The following is a description of a gene set: Any process that modulates the frequency, rate or extent of the phosphorylation of peptidyl-tyrosine. species: Homo sapiens Human Gene Set: GOBP_REGULATION_OF_PEPTIDYL_TYROSINE_PHOSPHORYLATION, and this is the list of marker genes: SOCS4, TNFSF18 (TNF superfamily member 18), VEGFA, PARP9, INPP5F, VPS25, EPHA7, FGFR3 (fibroblast growth factor receptor 3), IL12A, GPRC5B, RIPK2, CD80 (NCBI Gene Id 941), IL20, PTK6, FLT3, CASS4, PTPN1, RAP2C, CADM4, IFNG, ADAM17, ERRFI1, ABI1, PIBF1, PTPN2, FGF10, UNC119, FGF7, ITGB2, OSM, TGFB1, DMTN, CNTF, VEGFB, CTF1, TSG101, ZFYVE28, CHMP6, LILRA5, LIF, RAP2B, IL21, IL15, EFNA1, IL11 (interleukin 11), KIT, SNX6, ARHGEF2, TNK2, PDCL3, SOCS5, SAMSN1, EGFR, THBS4, CSPG4, IL31RA, SRCIN1, LACRT, ERBB4, PARP14, CNOT7, IFNL1, EFNA5, JAK2, NEDD9, NRG1, ZGPAT, DOK7, SFRP1, SFRP2, CSF1R, MVP, ENPP2, ABL1, IL18, ANGPT4, HES1, TNFRSF18, BANK1, ANGPT1, GPRC5A, ARL2BP, HRG, IL6